Given this list of marker genes Plekhm2, Pip4k2b, Vps39, Arl8b (ADP-ribosylation factor-like 8B), Plekhm1, Atp13a2, Znrf1, Tom1, Rubcnl, Pip4k2a, Cln3, Znrf2, Diaph3, here is a description of the gene set: studied in species Mus musculus The process in which autophagosomes, double-membraned vesicles containing cytoplasmic material, fuse with a vacuole (yeast) or lysosome (e.g. mammals and insects). In the case of yeast, inner membrane-bounded structures (autophagic bodies) appear in the vacuole. Fusion provides an acidic environment and digestive function to the interior of the autophagosome. Mouse Gene Set: GOBP_AUTOPHAGOSOME_LYSOSOME_FUSION